Given this list of marker genes PPIA, HMGCS1, FKBP3, PDK3, ALDOA, BNIP3L, AK4, EMILIN2, STAT5A, ENO3, HIGD1A, BCL2, NDUFV3, MT1F, GAPDH, ENO1, MIA2, OSTF1, SASH3, IFITM2, IFITM3, ANXA4, GPI, CORO7, HIKESHI, SLC25A1, here is a description of the gene set: from publication Brachat A, Pierrat B, Xynos A, Brecht K, Simonen M, Brüngger A, Heim J (PMID 12447701) Genes down-regulated in FL5.12 cells (pro-B lymphocyte) in response to methotrexate. Human Gene Set: BRACHAT_RESPONSE_TO_METHOTREXATE_DN DNA microarrays are powerful tools for the analysis of gene expression on a genomic scale. The importance of individual regulatory events for the process under study can however not be deduced unequivocally without additional experiments. We devised a strategy to identify central regulators of cancer drug responses by combining the results of microarray experiments with efficient methods for phenotypic testing of candidate genes. We exposed murine FL5.12 pro-B cells to cisplatin, camptothecin, methotrexate or paclitaxel, respectively and analysed the patterns of gene expression with cDNA microarrays. Drug-specific regulatory events as well as intersections between different apoptotic pathways, including previously studied responses to staurosporine and interleukin-3 (IL-3) deprivation, were identified. Genes shared by at least three pathways were chosen for further analysis. Ectopic expression of three such genes, TEAP, GP49B, and Lipin1 was found to have an anti-proliferative effect on pro-B cells. Interestingly, we identified hemoglobin alpha as a strong pro-apoptotic regulator. While hemoglobin-expressing cells were growing normally in the presence of IL-3, they displayed accelerated apoptosis with similar kinetics as Bax overexpressing cells upon IL-3 removal. The pro-apoptotic effect of hemoglobin was suppressed by Bcl-2 and was characterized by enhanced stimulation of caspase activity. species: Mus musculus